The following is a description of a gene set: Tall head relative to width and length. studied in species Homo sapiens Human Gene Set: HP_TURRICEPHALY Turricephaly, and this is the list of marker genes: SOX6, UFD1, FGFR1, ZFX, MEGF8, P4HB, FAM20C (FAM20C golgi associated secretory pathway kinase), GJA8, ERF, GP1BB, RREB1, SLC12A6, TWIST1, GPX4, HIRA, FGFR3, FHL1, FERMT1, CRTAP, JMJD1C, PEX5, SEC24D, KDM4B, SYT1, IL11RA, GJA5, POR, SLC25A24 (NCBI Gene Id 92093), ZIC1, TRIP11, SKI, ARVCF, SP7, RAB23, COMT, ALG14, TBCK, ACP5, SEC24C, AP1G1, RECQL4, TRPM3, RAB34, TBX1, PEX1, FGFR2 (fibroblast growth factor receptor 2), WBP4, MN1, MSX2